The following is a description of a gene set: Human Gene Set: MIR5006_5P species: Homo sapiens from publication Chen Y, Wang X (PMID 31504780) Genes predicted to be targets of miRBase v22 microRNA hsa-miR-5006-5p in miRDB v6.0 with MirTarget v4 prediction scores > 80 (high confidence targets)., and this is the list of marker genes: PPM1E, KCNAB3, ZBTB6, CDH18, DCN, SOS1, ARID4B, KCTD10, TTC19 (tetratricopeptide repeat domain 19), TMEM44, FGF2, PAK5, ENTPD3, FAM200B, FOXO3, CRIM1, CIT, PANK1, PNKD, KRT14, RPS6KA5, GTPBP2, RARB, ZDHHC21, TFCP2L1 (transcription factor CP2 like 1), ZNF180, PUM2, CSDC2, CHRNA5, DENND1C, CNIH4, FOXO1 (forkhead box O1), VMAC, TMC5, ATP10B, ADRA2B, EHD4, TMEM92, DHDDS, STYXL2, RASSF10, NME7, PAK2, TMEM131, CHSY3, PAX6, COPS7B, ARHGEF26, RIPOR2, CARD8, SRPK2, EME1, FLAD1, MXD3, MFN1, SIAH1, RALBP1, SPRY4, PCDH12, CRISPLD1, TDRD10, KLF6, KDM6A, UBE2V1, ARHGAP44, FAM111B (FAM111 trypsin like peptidase B), FZD8, SLC26A9, CAPNS2, CTNND1, THSD7A, MRC1, CDIN1, UBXN2A, RBBP6, CRACD, BICRAL, CSTF2, KCNB1, MGAT5B, CCDC62, MTMR4, C1QL4, PACS1, ZFHX4, CAMKV, COPZ2, KBTBD8, RRN3, FAM168A, MEF2A, FSHR, PLPPR4, BCL2L13, PHF24, MPPED2, PPP1R14C, CBS, SETDB2, CTDSPL, COTL1, PDE12, ZNF585A, SHISA9, PTAFR (platelet activating factor receptor), TBC1D10C, ASB14, DOCK9, C8orf34, TRIB2, DCUN1D1 (defective in cullin neddylation 1 domain containing 1), TGM4, NLGN2, POU3F2, CCBE1, GATAD2A, EML4, PNMA5, GOSR2, GM2A, ZNF827